Given this list of marker genes KCNN4, TRIP13, VHL, GPC3, WT1, PKLR, EGLN1, HBB, SLC30A10, FH, CYB5R3, ACVRL1, H19, SH2B3, EPOR, EDNRB, REST, HBA2, DIS3L2, CCND1 (NCBI Gene Id 893), BRCA2, POU6F2, ENG, EPO, JAK2, TRIM28, NAA10, PIEZO1, BPGM, SLC4A1, EPAS1, HBA1, here is a description of the gene set: Polycythemia is diagnosed if the red blood cell count, the hemoglobin level, and the red blood cell volume all exceed the upper limits of normal. Human Gene Set: HP_POLYCYTHEMIA Polycythemia studied in species Homo sapiens